The following is a description of a gene set: studied in species Homo sapiens Catalysis of the reaction: acetyl-CoA + an N-terminal L-alpha-aminoacyl- = CoA + H+ + N-terminal Nalpha-acetyl-L-alpha-aminoacyl-. Human Gene Set: GOMF_PROTEIN_N_TERMINAL_AMINO_ACID_ACETYLTRANSFERASE_ACTIVITY, and this is the list of marker genes: NAA40, NAA30, NAA80, NAA50, NAT9, NAA11, NAA20, NAA10, NAA60